Given this list of marker genes Ccr1, Ackr2, Ccr1l1, Xcr1, Cxcr6, Ccr3, Ccr2, Ackr1, Ccr6, Cxcr4 (NCBI Gene Id 12767), Zfp36, Ccr7, Cxcr5, Cxcr3, Ccr8, Cx3cr1, Ccrl2, Cxcr2, Cxcr1, Ackr3, Ccr5, Ccr9, Ackr4, Ccr4, Ccr10, here is a description of the gene set: Mouse Gene Set: GOMF_C_C_CHEMOKINE_BINDING Binding to a C-C chemokine; C-C chemokines do not have an amino acid between the first two cysteines of the characteristic four-cysteine motif. studied in species Mus musculus